The following is a description of a gene set: Catalysis of the reaction: glucuronate acceptor + UDP-alpha-D-glucuronate = acceptor beta-D-glucuronoside + H+ + UDP. Mouse Gene Set: GOMF_GLUCURONOSYLTRANSFERASE_ACTIVITY studied in species Mus musculus, and this is the list of marker genes: Chsy1, Ugt1a5, Ugt1a6a, Ugt2a2, B4gat1 (NCBI Gene Id 72430), Ugt2b34, Ugt2a3, Ugt1a8, B3gat1, B3gat3, Chpf, Ugt1a9, Ugt2b5, B3gat2, Chsy3, Ugt2b35, Ugt2b36, Ugt3a1, Large1, Ext2, Ugt2a1, Ugt1a10, Ugt2b1, Large2, Ugt1a1, Chpf2, Csgalnact1, Ugt3a2, Ugt2b37, Ext1, Extl1, Ugt1a7c, Ugt1a6b, Ugt2b38, Ugt1a2